Given this list of marker genes Trim56, Trim30a, Tmeff1, Ifitm7, Trim11, Trim5, Ifitm1, Trim25, Snx3, Trim31, Ly6e, Trim30d, Ifitm2, Rad50, Trim10, Trim8, Trim30c, Ifitm6, Trim30b, Fcnb, Cd74, Ifitm3, Trim12a, Ptx3, Apcs, Mre11a, Nbn, Ciita, Lrrc15, Trim26, Gsn, Trim59, Trim12c, Mid2, here is a description of the gene set: species: Mus musculus Mouse Gene Set: GOBP_HOST_MEDIATED_SUPPRESSION_OF_SYMBIONT_INVASION A process in which a host inhibits or disrupts the entry of a symbiont into a host cell.